The following is a description of a gene set: part of: Downstream signaling of activated FGFR4 Reactome Pathway: FRS-mediated FGFR4 signaling studied in species Homo sapiens The FRS family of scaffolding adaptor proteins has two members, FRS2 (also known as FRS2 alpha) and FRS3 (also known as FRS2beta or SNT-2). Activation of FGFR tyrosine kinase allows FRS proteins to become phosphorylated on tyrosine residues and then bind to the adaptor GRB2 and the tyrosine phosphatase PPTN11/SHP2. Subsequently, PPTN11 activates the RAS-MAP kinase pathway and GRB2 activates the RAS-MAP kinase, PI-3-kinase and ubiquitinations/degradation pathways by binding to SOS, GAB1 and CBL, respectively, via the SH3 domains of GRB2. FRS2 acts as a central mediator in FGF signaling mainly because it induces sustained levels of activation of ERK with ubiquitous expression.<br><br><br>, and this is the list of marker genes: PTPN11, KLB, GRB2, FGF16, FRS2, FGF18, FGF19, KRAS, FRS3, FGF6, HRAS, FGF8, FGF23, FGFR4, FGF17, FGF2, SOS1, FGF9, NRAS, FGF20, FGF4, FGF1